The following is a description of a gene set: ARMS-mediated activation Mouse Gene Set: REACTOME_ARMS_MEDIATED_ACTIVATION studied in species Mus musculus, and this is the list of marker genes: Kidins220, Crk, Rap1a, Ntrk1, Ngf